The following is a description of a gene set: species: Homo sapiens from publication Chen Y, Wang X (PMID 31504780) Genes predicted to be targets of miRBase v22 microRNA hsa-miR-4714-5p in miRDB v6.0 with MirTarget v4 prediction scores > 80 (high confidence targets). Human Gene Set: MIR4714_5P, and this is the list of marker genes: ZNF780A, ETNK1, TBP, RPH3AL, PRR20D, MDGA2, DEGS1, ZNF595 (NCBI Gene Id 152687), TAF1B (TATA-box binding protein associated factor, RNA polymerase I subunit B), LAP3, HRH4, CAMTA1, FAM169A, DST, PRR20C, KRT12, KCNB1, IKBIP (NCBI Gene Id 387877), KPNA1, PRR27, ONECUT2, SH3BGRL2 (SH3 domain binding glutamate rich protein like 2), STX16, ZNF674, SERTAD4, FAM53A (NCBI Gene Id 152877), SLC45A3, PRR20B, GINS4, LRATD2, ZNF721, PTPN11, ARL8B (ADP ribosylation factor like GTPase 8B), GAGE1, SMLR1, EEA1, NEFL, SLC25A15, PRKG2, DUSP4, MAP2, CEP85, TECTB (tectorin beta), RPL31, PPIE, HADHA (NCBI Gene Id 3030), SVIL, RASL11A (NCBI Gene Id 387496), ACSM5, SNAP23, G3BP1, TTC7B, ZNF805, SLC22A3, ZNF273, ZNF71, MAP4K4, PRR20A, ZNF77, GCNT4, COL21A1, GFPT2, ARHGEF38, TSPAN6, GABRB2, SESN3, COX11, C1orf198, FAM78B, LCT, RHOU, CUX2, HOMEZ, C17orf67, ATP8A2, SESTD1, PHTF2, PRR20E, C6orf62, DDX46, TMEM41B, TCAIM, PGAP4, GABRA2, AKR7A2, ABCB10, RNF170, SLC30A4, YTHDC1, QNG1 (Q-nucleotide N-glycosylase 1), ADAMDEC1, ZNF718, PPM1E, PTPRQ, SV2C, LRP8, MANEA, PSMC2, SHOC2 (NCBI Gene Id 8036), TNS3, ZNF37A, STOX2, SELENOT, SAP30L, ARL6IP6